The following is a description of a gene set: The chemical reactions and pathways resulting in the breakdown of GMP, guanosine monophosphate. Mouse Gene Set: GOBP_GMP_CATABOLIC_PROCESS studied in species Mus musculus, and this is the list of marker genes: Nt5c2 (5'-nucleotidase, cytosolic II), Gmpr2 (guanosine monophosphate reductase 2), Urad, Hprt1, Gda, Uox, Xdh, Pnp, Urah